The following is a description of a gene set: Pathway Definition from KEGG: EspJ -| SRC -> FCGR species: Homo sapiens Human Gene Set: KEGG_MEDICUS_PATHOGEN_ESCHERICHIA_ESPJ_TO_IGG_FCGR_RAC_SIGNALING_PATHWAY Escherichia EspJ to IGG-FCGR-RAC signaling pathway. Pathway ID: N01091. Pathway type: Pathogen. Pathway class: nt06135 Cytoskeletal regulation (viruses and bacteria)., and this is the list of marker genes: FCGR3A (Fc gamma receptor IIIa), FCGR3B, SRC, FCGR1A, FCGR2A